Given this list of marker genes SLC4A4, FUT6, PTPRO, CIAO1, CCR2, MYOF, AP1M2, NALF2, RPN2, LYPLAL1, CREB1, BRD10, SLU7, KRR1, ATG3, MIR25, RAPSN, SLC25A51, RAB18, OTP, IPP, UFSP2 (NCBI Gene Id 55325), RASSF6, SEM1, ING3, TMSB4X, PCYOX1, SPTY2D1 (NCBI Gene Id 144108), CD1C, FAM200A, TAF15 (TATA-box binding protein associated factor 15), PTGR2, FUT8-AS1, PHAX, ZFYVE27, NFKBIZ, C4orf3 (NCBI Gene Id 401152), here is a description of the gene set: Human Gene Set: ANDERSON_BLOOD_CN54GP140_ADJUVANTED_WITH_GLA_AF_AGE_18_45YO_6HR_UP Systems biology approaches have recently provided new insights into the mechanisms of action of human vaccines and adjuvants. Here, we investigated early transcriptional signatures induced in whole blood of healthy subjects following vaccination with a recombinant HIV-1 envelope glycoprotein subunit CN54gp140 adjuvanted with the TLR4 agonist glucopyranosyl lipid adjuvant-aqueous formulation (GLA-AF) and correlated signatures to CN54gp140-specific serum antibody responses. Fourteen healthy volunteers aged 18-45 years were immunized intramuscularly three times at 1-month intervals and whole blood samples were collected at baseline, 6 h, and 1, 3, and 7 days post first immunization. Subtle changes in the transcriptomic profiles were observed following immunization, ranging from over 300 differentially expressed genes (DEGs) at day 1 to nearly 100 DEGs at day 7 following immunization. Functional pathway analysis revealed blood transcription modules (BTMs) related to general cell cycle activation, and innate immune cell activation at early time points, as well as BTMs related to T cells and B cell activation at the later time points post-immunization. Diverse CN54gp140-specific serum antibody responses of the subjects enabled their categorization into high or low responders, at early ( < 1 month) and late (up to 6 months) time points post vaccination. BTM analyses revealed repression of modules enriched in NK cells, and the mitochondrial electron chain, in individuals with high or sustained antigen-specific antibody responses. However, low responders showed an enhancement of BTMs associated with enrichment in myeloid cells and monocytes as well as integrin cell surface interactions. Flow cytometry analysis of peripheral blood mononuclear cells obtained from the subjects revealed an enhanced frequency of CD56<sup>dim</sup> NK cells in the majority of vaccines 14 days after vaccination as compared with the baseline. These results emphasize the utility of a systems biology approach to enhance our understanding on the mechanisms of action of TLR4 adjuvanted human vaccines. species: Homo sapiens Genes up-regulated in blood 6hr vs 0hr in adults (18-45) after exposure to CN54gp140 adjuvanted with GLA-AF, time point 6H, administered i.m. from publication Anderson J, Olafsdottir TA, Kratochvil S, McKay PF, Östensson M, Persson J, Shattock RJ, Harandi AM (PMID 29535712)